The following is a description of a gene set: species: Homo sapiens Human Gene Set: GOBP_REGULATION_OF_B_CELL_APOPTOTIC_PROCESS Any process that modulates the frequency, rate, or extent of B cell apoptotic process., and this is the list of marker genes: IL10, IL2, NOC2L, MIF, BCL6, BCL10, ADA, IRS2, CD74 (NCBI Gene Id 972), BTK, PDCD1, FNIP1, LYN, HSH2D, SLC39A10, FOXP1, ORMDL3, BCL2, AURKB, MIR17HG (NCBI Gene Id 407975), BAX, MYC